Given this list of marker genes TUBA1B, AP2M1, TUBA4A, SH3GL2, DNM3, RPS6KA6 (NCBI Gene Id 27330), AP2A1, TUBB6, AP2S1, KIF4B, RPS6KA2, RPS6KA3, TUBB4B, ACTG1, TUBA3C, SHTN1, TUBB4A, RPS6KA4, TUBB8B, TUBB2B, TUBA1C (NCBI Gene Id 84790), TUBB1, RPS6KA1, ACTB, AP2A2, NUMB, TUBB2A, DNM1, CLTC, SRC, DNM2, MSN, L1CAM, TUBA8, DPYSL2, EZR, CLTA, TUBA3E, KIF4A (NCBI Gene Id 55595), AP2B1 (adaptor related protein complex 2 subunit beta 1), TUBA1A, TUBA3D (NCBI Gene Id 150778), TUBA4B, TUBB8, MAPK1, TUBAL3, RPS6KA5, TUBB3, RDX, here is a description of the gene set: Human Gene Set: REACTOME_RECYCLING_PATHWAY_OF_L1 species: Homo sapiens Recycling pathway of L1